The following is a description of a gene set: Abnormal tendon morphology An abnormality of the structure or form of the tendons, also often called sinews. species: Homo sapiens Human Gene Set: HP_ABNORMAL_TENDON_MORPHOLOGY, and this is the list of marker genes: NHLH2, IL10, UPF3B, KLHL40, ALG2, IL6ST, SIGMAR1, CDC42, CAVIN1, ECEL1, DPAGT1, PLOD3, POLE, PLOD2, TMEM107, TMEM218, FGF17, RERE, CHMP1A, IDS, NRCAM, KLHL7, UBA1, MT-TE, GJA8 (gap junction protein alpha 8), SUZ12, DLK1 (NCBI Gene Id 8788), HOXD13, RYR3, SYNE2, CTDP1, SLC12A6, KIF14, CCDC32, EPHX2, ZDHHC9, DRG1, BLTP1, RIC1, SDHD, AIMP1, TGFB2, DVL3, SUCLG1, POLD1, FGFR1, SLC5A7, GNPTG, ELOVL4, KBTBD13, IL2RB, TWIST2, SLC26A2, NUP133, COQ7, EIF5A, CHRNG, NEDD4L, MMP2, PIK3C2A, RAB3GAP2, ABCD1, VPS53, FLVCR2, PEX2, PAX3, GLI3, DST, KIF5A, BRPF1, SMPD4 (sphingomyelin phosphodiesterase 4), ARSB, PRDM5, GPKOW, ATP5F1D, LMNA, CASZ1, MTRFR, CANT1, FAM111B, VAMP1, MLH1, PIK3R2, H3-3A, SEMA4A, PPT1 (NCBI Gene Id 5538), TBCD, MYL11, H4C9, RNU4ATAC, KAT6B (NCBI Gene Id 23522), POLR3GL, MRPS34, LIFR, ACADS, HK1, MECR, DLL1, KIF1A, SNRPB, IGF2 (insulin like growth factor 2), MORC2, CCR6, SLC4A10, COL3A1, STAG2, TBX3, MYO18B, P4HTM, SMOC1, SLC2A10, PLEC, ZBTB20, SPTBN4, NEFL, VPS33B, NSD1, RFT1, UNC80, FILIP1, FKRP, ADSS1, STAT4, EMILIN1, CHEK2, GABRD, ASCC1, KRT16, SYNE1, ALG1, PMM2, NKAP, FITM2, GCK, ADGRG6, RARS2, FBN2, SLURP1, DCX, ATP2A1, NUP107, GJA1, HBA2, SMC1A, THOC6, CHST14, NSDHL, KCNK9, MAF, BGN, CRKL, NDE1, MEG3, DLL3, HIKESHI, PIGN, PRG4, PDXK, SMAD4, BRF1 (NCBI Gene Id 90137), KDM5B, TACR3, SGCG, VWA1, ZMPSTE24, DHODH, ITCH, NUP188, COL1A1, TNPO3, PHGDH, MYL2, PTPN2, KMT2A, JUP, ABCG5, CAMLG, LTBP4, SLC6A9, COG8, SPEG (NCBI Gene Id 729871), RNF113A, MEGF10, NDUFAF4, SCYL2, EP300, SON, ZBTB42, IFIH1, RAB23, MUTYH, RFC1, SLC29A3, PEX5, KCNJ6, SMS, RBM28, SAMHD1, DSE, SVIL, NR4A2, KLHL9, PMP22, IRF5, CDC6, ANTXR2, ATAD1, KLC2, RPL10, POMT2, GJB6, FIG4 (FIG4 phosphoinositide 5-phosphatase), CCBE1, CCN6, GRIN1, SMARCA2, NKX3-2, CHN1, STAC3, GBA1, PROK2, SPRTN, ABCC9, LARGE1, GPT2, INF2, IBA57, ZNF335, PAX7, ECE1, PPP2R5D, FUT8, KRAS (KRAS proto-oncogene, GTPase), BRCA2, ALG9, EPCAM, TTPA, CCN2, MTM1, ARL6IP1, KISS1R, CHRNB1, NIPBL, USP7, NPPA, KRT14, PTPN22, APOE, CREBBP, SDHAF1, GJB1, AP4E1, SATB2, CDK13, TREX1, YRDC, FBN1, ACADM, MYH7, ALDH3A2, TUBA1A, MED11, GJA5, ATRX, TRPS1, SPTAN1, CHAT, TLK2, MYO9A, TDO2, PIGL, VIPAS39, GLI2, DLG5, GOLGA2, CTCF, KIF21A, MYL1, RMRP, TRIP13, SLC25A19, B3GALT6, MAP3K7, C18orf32 (chromosome 18 open reading frame 32), GNPTAB (N-acetylglucosamine-1-phosphate transferase subunits alpha and beta), APOB, YY1, COL11A1, BMPR1A, ADAMTS3, DVL1, DEGS1, FGF8, MPDU1, EZH2, ABHD12, SIN3A, VMA21, MEGF8, HPDL (4-hydroxyphenylpyruvate dioxygenase like), TBX4, SF3B4, FAT4, OPA1, FAM20C, BIN1, CRPPA, CNTNAP1, REV3L, SLC25A4, MKS1, NGLY1, POU3F4, REEP1 (receptor accessory protein 1), PMS1, TPM2, TP53RK, TNNI2, CIITA, PLCH1, EED, ABCC8, ORC6, AP4S1, DNM2, SLC22A4, TBC1D20, SLC1A2, HGD, STAT3, DSP (desmoplakin), VARS1, DDC (dopa decarboxylase), ATP6V1E1, BICD2, FBXO11, FKBP10, SGCA, MYH2, KRT1, SPRY4, LZTR1, UCHL1, GAD1, MED12, PEX7, SDHB, CHRNA1, MUSK, GPC4, PLAAT3, LSS, SHH, TNNC2, FLVCR1, KIF5C, PLXND1, CACNA1E, CD244, SIK3, KY, SETBP1, CPT2, EXOC8, VPS11, FDFT1, FOXH1, SLC18A3, AP1S2, GAN, DISP1, GUSB, ERCC1, SIX3, WDR73, KIDINS220, MED25, ALX3, LAMB3 (laminin subunit beta 3), FKTN, ABL1, PEX6, MSL3, ESCO2 (NCBI Gene Id 5951), TGM1, TMEM222, DNAJB6, NOG, CFL2, SALL4, EXTL3, SDHA, COL6A1, ASXL3 (ASXL transcriptional regulator 3), PERP, SLC25A1, TPM3, CACNA1C, ZNF407, POGZ, CARS1, EXOSC3, HACD1, SPEN, PYCR1, ORC1, DYM, COG3, COL1A2, KIAA0753, LUZP1, POLR3A, PTRH2, SLC1A4, MYMK, BCOR, NXN, FANCC, NKX6-2, ADAMTSL2, TCTN3, AMER1 (APC membrane recruitment protein 1), DAG1, PIGP, TBX2, SLC39A13, COL25A1, TUBB3, HRAS, TBC1D2B, B3GAT3, ERCC3, GNB2, RNF13, FUCA1, NODAL, KRT9, LONP1, GHR, MMP23B, HS2ST1, PLP1, EPB41L1, LMNB1, PSMB4, IPO8, SLC9A6, CUL4B, COG5, NSUN2, EXOC7, GBA2, WDR4, ANKLE2, PRKCZ (protein kinase C zeta), PTCH1, AIMP2, FBXO28, TGIF1, PHF6, CCDC47, AARS1, SMARCAD1 (SWI/SNF-related, matrix-associated actin-dependent regulator of chromatin, subfamily a, containing DEAD/H box 1), SH3PXD2B, PDGFRB, LAMA2, PLA2G6, PYROXD1, MLXIPL (MLX interacting protein like), ALS2, HSPB1, RTL1, ARX, TTR, NT5C2, ALG8, STX5, ADAT3, PSAT1, BCAS3, AGTPBP1, EBP, GRID2, MTX2 (NCBI Gene Id 10651), L1CAM, MYH8, PPP1R21, PEX1, GMNN, OTUD5, PRUNE1, GDF5, LAMA5, WNT5A (NCBI Gene Id 7474), TGFB3, DDR2 (discoidin domain receptor tyrosine kinase 2), CRIPTO (NCBI Gene Id 6997), COASY, SPTLC1, POLR1A, MET, CHD7, CDT1, SPG11, LDLR, PIGY, SLC35A2, SIL1, VPS33A, RNASEH2B, KCNAB2, TRAK1, KIF26A, HINT1, ATP6V1A, BRAT1 (BRCA1 associated ATM activator 1), GORAB, COL2A1, AHSG, GRIA4, GFPT1, PDHA1, MPLKIP, GNPAT, ADAR, CEP55, APOA1 (NCBI Gene Id 335), GPC3, TRAF7, FOXP1, SYT2, HES7, NACC1, SCARF2, ACTA1, LIAS, GDAP1, ACTG2, GNPNAT1, TRPV3, LSM11, COL17A1, IGHMBP2, ORAI1, GARS1, ASXL1, POP1, CADM3, PLOD1, EXOSC9 (NCBI Gene Id 5393), MED13L (mediator complex subunit 13L), PSMB8, NCAPG2, DPH2, ARPC4, PRDM16, MSH2, KCNN3, ATR, AIFM1, LDLRAP1, SPTSSA, TOR1AIP1, MBTPS2, SNUPN, CHRNE, PNPT1, TRIP4, FLNA, TGFBR1, KMT2B, FZD2, CACNA1A, STIM1, RNASEH2C (ribonuclease H2 subunit C), CLDN11, COX11, ERLIN2, LAGE3, APC2, ERCC5, ERCC8, KIF22, PQBP1 (polyglutamine binding protein 1), CYP27A1, BAG3, CDON, HSPG2, STIL, ITGB6, PTDSS1, LMOD3, WRN, FCSK, ZPR1, VRK1, FLRT1, IL2RA, FBXW11, COL7A1, TAF4, ERI1, PYCR2, TBX15, UROS (NCBI Gene Id 7390), EXOSC5, WNT7A, TGDS, HUWE1, SHPK, SLC39A14, SNX14, FERMT1, RYR1, PROKR2, MYOD1, CLPB, SOX9, NFATC2, LGI4, DMD, ERBB3 (NCBI Gene Id 619500), NUP88, FLNC, PDPN, CCDC22, GFM2, PSMG2, WIPI2, RIPK4, MAGEL2, H1-4, DHX16 (NCBI Gene Id 8449), IDUA, TBCK, BCR, TNNT1, RTTN, KIAA0319L, BHLHA9, BANF1, PIP5K1C, SELENON, TFAP2A (NCBI Gene Id 95131), KDM5C, ADAMTS15, OTUD6B, NLRP3, ALDH18A1 (NCBI Gene Id 9193), NAA10, CHRND, DHCR24, RNASEH2A, PMS2, ACER3, HEXB (NCBI Gene Id 3074), POMT1, WDR11, MMP1, NSMF, MFN2, POR, PI4KA, EXOC2, LFNG, TGFBR2, PIGS, SPART, CDC45, MAPK1, ZNF469, COQ4, HLA-DRB1, IKBKG, NOD2, ZC4H2, ATM, PPP3CA, SLC10A7, SOX10, ERLIN1, PIK3CA, NEB, GBE1, GSC, CAV1, FGFR2, PLEKHG5, ATP11A, FHL1, SNAP25, ANO5, ERCC6, FGD1, SMAD3, RAB3GAP1, ATPAF2, RIPPLY2, CDH3, GLUL (glutamate-ammonia ligase), MESP2 (mesoderm posterior bHLH transcription factor 2), CRLF1, LEMD3, GAS1, PIGA, B4GALT7, KL (klotho), PHACTR1, DCHS1, GON7, GNRH1, GMPPB, SYT1, IDH1 (NCBI Gene Id 3417), CLCN3, EFNB1, ALX1, AGRN, CLIC2, OCRL, ORC4, SEPSECS (Sep (O-phosphoserine) tRNA:Sec (selenocysteine) tRNA synthase), LMBRD2 (NCBI Gene Id 92255), PCNA, GTF2E2, MARS1, PTH1R, DPM1, DUSP6, ALG14, TSEN54, WDR45B, MECP2, COL6A2, HSPD1, CLCF1, JARID2, DDHD2, UFC1, ANKRD55, ERGIC1, LMX1B, PTF1A, ELN, COL12A1, ITGA7, TAPT1, F8, SLC35A3, RPS20, SMG9, ITGB4, MYBPC1, SCN4A, ERCC4, TMEM70, SKI, TARS1, MYOT, COG1, DPH1, PSTPIP1, TAC3, CAPN3, CHST3, TELO2, GTF2H5, ALG13, EXOSC8, SCN5A, HBA1 (NCBI Gene Id 3039), SLC25A46, TRIM2, APOA2, ALG3, DYRK1A, RSPO2, KIF15, NARS1, AP4B1, LMBR1, MAFB, UBAP2L, FUS (FUS RNA binding protein), COL13A1, MYH3 (myosin heavy chain 3), DARS2 (aspartyl-tRNA synthetase 2, mitochondrial), ZEB2, PIEZO2, RNU7-1, NEK9, DPM2, KCNJ11, ALAD (aminolevulinate dehydratase), ARID1B, TTN, FGFR3, KISS1 (KiSS-1 metastasis suppressor), TPRKB, AUTS2, COL11A2, JAG2, TP63, NALCN, TFG, OSGEP, GNRHR, ZNHIT3, SLC39A8, TMEM43, PLAA, ERCC2, MTMR14, LBR, XYLT1, TOR1A, SLC16A2, NFKBIL1, HNRNPA2B1, ADGRG1, INS, ASAH1, SMAD2, SRD5A3, C19orf12, HS6ST1 (NCBI Gene Id 9394), IARS2, GCH1, RAB18, FIBP, GNS, PORCN, TRPV4, CDK5, NSRP1, NDRG1, TNNT3, ADCY6, PDX1, UBE4B, SEC31A, IMPDH2, MSH6, ABCG8, MAP3K20, HNRNPA1, GJB2, DNA2, CNTN1, ROR2, THBS2, TBR1, POMK, COL6A3, KLHL41, CD247, ZIC2, EMD, MYPN, PRKCG, GLDN, EMG1, DOK7, MAN1B1, PPP1R17, SRPX2, LPIN2, CSGALNACT1, B9D2, GLE1, ALG12, WDR26, PCSK9, RAPSN